The following is a description of a gene set: Human Gene Set: GOMF_HISTONE_H3K9_DEMETHYLASE_ACTIVITY species: Homo sapiens Catalysis of the removal of a methyl group from a modified lysine residue at position 9 of the histone H3 protein., and this is the list of marker genes: KDM4E, KDM7A, PHF2, KDM4C, KDM4F, KDM4D (lysine demethylase 4D, NCBI Gene Id 55693), KDM1A, KDM3B, KDM3A, HR, KDM4A, JMJD1C, PHF8, KDM4B